The following is a description of a gene set: Human Gene Set: GSE37532_WT_VS_PPARG_KO_VISCERAL_ADIPOSE_TISSUE_TCONV_DN studied in species Homo sapiens from publication Cipolletta D, Feuerer M, Li A, Kamei N, Lee J, Shoelson SE, Benoist C, Mathis D (PMID 22722857) Genes down-regulated in T conv from visceral adipose tissue in aged mice: wildtype versus PPARG knockout. We identified Pparg as a major orchestrator of the phenotype of adipose-tissue resident regulatory T cells (VAT Tregs). To establish the role of Pparg in shaping the VAT Tregs gene profile and cell dynamics, Tregs from lymph nodes and visceral adipose tissue of mice sufficient and deficient of Pparg expression in Tregs were double sorted for microarray analysis., and this is the list of marker genes: UROD, GET1 (guided entry of tail-anchored proteins factor 1), PLIN2, RRP1B, PFN2, LHFPL2, CDC40, MREG, MYO1B, SUPT16H, LASP1, PAXIP1, RRS1, SNX13, FEM1B, ZBTB14, GTF2E1, BNIP3L, PRPF38B, SNX4, IER3 (immediate early response 3), GPER1, PHF20, LIAS, TMEM168, KATNB1 (katanin regulatory subunit B1), UNC119B, SNUPN, RBM38 (RNA binding motif protein 38), MAGEF1, TIMM8A, INTS15, BID, APEX1, B4GALT6, PAGR1, USP22, TIMM8B, ARRB1, SEPHS1, TJP2, IMPA2 (NCBI Gene Id 3613), ANP32B, ADGRG1, KDM1A, MORC2, FANCE, FXN, FAM200C, HNRNPA0, UBE2I, U2SURP, GRAMD4 (NCBI Gene Id 23151), PIDD1, SNRPD1, NACC2, USP20, BAIAP2, USP12, HEATR1, RBMX, ACO1, CFAP20, DHX57, NARS2, NUFIP1, HMG20A, MEGF9, PINK1, SLC25A36, FBXO28, NT5DC2, TOMM20, PMPCA, PHF10, FBL, EEF1E1, CTNNAL1, MYCL, ACP6, RGP1, BZW2, COTL1, NRG1, SFPQ, ABHD10, PDXDC1 (pyridoxal dependent decarboxylase domain containing 1), AGPAT5, CLNS1A, EBP, TCEAL1, ASTE1, MCMBP, AMPD2, KCTD7, ATP5PB (ATP synthase peripheral stalk-membrane subunit b), TSPAN6, SAMSN1, ZFP64, GAMT, TCFL5, NOL11, CUL3, PABPC4, FEZ1, TFDP1, ARB2A, TRAK2, DOK4, ANKRD28, PSMG1, ROR1, SIK2, MAEA, NINL, IL11, UBE4B, C1orf174, SLC26A2, RMND5A, SNN, PRDX2 (peroxiredoxin 2), BLCAP (NCBI Gene Id 10904), SFMBT1, DUSP7, CCNF, GALNT11, LRPPRC, DNAAF2, CENPS, FAM53C, DAD1, OXA1L, GPATCH3, PDLIM2, MAPK14, LRRC8D, ATG4A, THAP4, CXADR, RPP40, OLA1, GORASP2, PDZD8, UTP25, SMARCC1, CERK, THEM6, PMPCB, REPIN1, HILPDA, NSMF, PKIA, LMCD1 (NCBI Gene Id 29995), BICD2 (NCBI Gene Id 23299), NARS1, DLG1, RAB4A, TSR1, POLR2F, PELI2, EZH2, DAP3, NOLC1, GPN3, CRKL, PARG, SCRIB, WIPI2, MTMR4, GCDH, SLC25A13, ITGAE, RCL1, ZFTA, STX6, KMT5B, DKC1, THYN1, PACSIN3, ANGEL1, PARK7, DDX50 (NCBI Gene Id 79009), UMPS (uridine monophosphate synthetase), ZMAT3, TACC2, USP3, ATG4B, WDR12, FRG1, BRCC3, MOSPD1, MN1, CDC42EP3, UNKL, JPT2, CARD10, PAK2, CHST2, PARP2